Given this list of marker genes Sting1, here is a description of the gene set: Reactome Pathway: STAT6-mediated induction of chemokines electronically inferred by orthology from the curated human pathway part of: STING mediated induction of host immune responses studied in species Mus musculus This event has been computationally inferred from an event that has been demonstrated in another species.<p>The inference is based on the homology mapping from PANTHER. Briefly, reactions for which all involved PhysicalEntities (in input, output and catalyst) have a mapped orthologue/paralogue (for complexes at least 75% of components must have a mapping) are inferred to the other species.